Given this list of marker genes Apoc2l, Apoh, Gpld1, Lipe, Pnpla5, Lipc, Lipg, Pnpla3, Apoc2, Apoc3, Pnlip, Ddhd2, Abhd5, Aadac, Pnliprp2, Fgf21, Daglb, Plin5, Pnliprp1, Ldlr, Apoa4, Pik3cg, Apob, Sorl1, Mgll, Cps1, Plb1, Gpihbp1, Lpl, Pnpla2, Pnpla1, Apoa5, here is a description of the gene set: Mouse Gene Set: GOBP_TRIGLYCERIDE_CATABOLIC_PROCESS species: Mus musculus The chemical reactions and pathways resulting in the breakdown of a triglyceride, any triester of glycerol.